The following is a description of a gene set: Mouse Gene Set: GOBP_RESPONSE_TO_POTASSIUM_ION Any process that results in a change in state or activity of a cell or an organism (in terms of movement, secretion, enzyme production, gene expression, etc.) as a result of a potassium ion stimulus. studied in species Mus musculus, and this is the list of marker genes: Adamts13, Slc26a5, Crhbp, Acta1, Kcnc1, Hnrnpa1, Nptx1, Atp1a2, Abcc9, Mylk, Slc12a2, Nek7, Kcnj10, Mecp2, Stk39, Kmt2a, Dlg4, Dlg2, Atp1a3